Given this list of marker genes TNFAIP8L1, IFT25, LAYN, MRPL35, TRAP1, LEAP2, LTA, DTD1, GNA15, PHPT1, ATP5MC3, RCC1L, BMAL2, RNGTT, PSMB2, CKS2 (NCBI Gene Id 1164), OXSR1, CRNKL1, DNAJC9, CENPW, IARS2, EFCAB3, CHAF1B, HCP5, EXO1, LSM4, DDIT4, ARMT1, CETN3, CDC25A, SPINT2, CAPG, UBAC2, SPAG16, SMYD3, MEAK7, FEN1, SNX3, SDHAF4, RAB20, SNX12, FPGT, RHOC, CCDC34, MRPL37, NUDT6 (nudix hydrolase 6), RBM41, POLB, ACSS2, NFXL1, SKA3, GPR157, MRPL18, RPP30, KIF2A, MAD2L2, NUP88, PPCDC, FADD, HPRT1, DPAGT1, ZNF367, NEMP1, MAP2K1, KEAP1, CENPJ, CORO1B, ANKZF1, B3GALT4, EGLN3, IDH2, PRDX4, BLM, COX5A, RBM6, DUT, PARK7, NUDCD1, P4HA1, NCKAP1L, ARL6IP1, SFT2D1, DNAJC17, PGRMC1, TRIQK, GRK3, CYTIP, DNMT1, ATP5MF, GBP2, BCAT1, MRPL17, PLTP, FAF1, PLCXD1, ERG28, KLF10, PLAC8, C10orf88, SLC25A11, ATP23, TREX1, RFC2, STXBP1, SUPT20H, LDHC, POLR3D, LINC00526, DBI, SNRPD3, SND1, TRIM4, CCNF, SLC9A3-OT1, CAMK1, KDM7A-DT, COMMD8, DTYMK (NCBI Gene Id 9102), LINC01128 (NCBI Gene Id 647710), FBXO22, LEPR, POLR2H, COX8A, NSD2, FHOD1, HNRNPUL2, CCNA2 (cyclin A2), PSMG1, TMEM263, EVI2A, WDHD1, ZNF410, HNRNPA2B1, YARS2, COPS5 (COP9 signalosome subunit 5), LRRFIP2, CENPF, CD53, VBP1, APOBEC3G, CERS2, RUVBL2, STAMBPL1, C11orf24, GNGT2, HNRNPLL, INTS2, SFN, TRIP10, DNAH14, BCKDK, LRRC42, PDHA1 (pyruvate dehydrogenase E1 subunit alpha 1), TPD52, VDAC1, TMEM65, EED, INTS6 (integrator complex subunit 6), IMMT, GLE1, EBI3, ELP5, RECQL4, SPATC1L, FRMD6, MRRF, NGLY1, ZCCHC17, EBP, VPS26C, WRAP53, CCT4, TRIB3 (tribbles pseudokinase 3), KTN1, PHF19, PDAP1, DNAAF10, CHMP5, SAPCD2, UBL5, SMIM7, MTA3, PPID, CD82, TK1, DCP1B, SHMT1, DHRS1, MCM5, PTPN22, ERLIN1, HSCB, PAK1, MRPL23, IRF4, DLEU1, PPP1CA, ATP5IF1, GALK1, DYM, here is a description of the gene set: Human Gene Set: GSE17974_0H_VS_72H_IN_VITRO_ACT_CD4_TCELL_DN Genes down-regulated in comparison of untreated CD4 T cells at 0 h versus the untreated cells at 72 h. The aim of this dataset was to study in detail the transcription kinetics initiated by cytokine IL-4 in early differentiation of Th2 cells. from publication Elo LL, Järvenpää H, Tuomela S, Raghav S, Ahlfors H, Laurila K, Gupta B, Lund RJ, Tahvanainen J, Hawkins RD, Oresic M, Lähdesmäki H, Rasool O, Rao KV, Aittokallio T, Lahesmaa R (PMID 20620947) studied in species Homo sapiens